Given this list of marker genes PTEN, FUCA1, SEC23B, KRT10, SDHD, GJB3, SDHC, AKT1, PIK3CA, SDHB, LMNA, USF3, KLLN, ZMPSTE24 (NCBI Gene Id 10269), here is a description of the gene set: Human Gene Set: HP_GENERALIZED_HYPERKERATOSIS studied in species Homo sapiens Generalized hyperkeratosis